Given this list of marker genes Cfap119, Cdin1, Mybl2, Cryl1, Cd247, Fgfr2, Prep, Osm, Pck1, Nhp2, Rasl2-9, Creb3l1, Dusp9, Nova1, Clcn6, Alad, Fbxo22, Vapa, Cox16, Ppp2r5d, Aar2, Zfp933, Phyhip, Ctdsp2, Psmb2, Srf, Mlst8, Ebp, Arf3, Nom1, Chrna4, Gspt1, Zbtb16, Cdh5, Ctsd, BC016579, Nmt2, Rnasek, Babam1, P2rx4, Laptm5, P4ha1, Efhc1, Mdga1 (MAM domain containing glycosylphosphatidylinositol anchor 1), Kdm6b, Zfp992, Tmprss11b, D630039A03Rik, Cdcp3, Lamc1 (laminin, gamma 1), Hcfc1, Ebf3, Arhgap32, Zswim8, Clcf1, Mapkapk2, Kat6a, Elavl2, Mbd6, Cd300ld, Otof, Hsd3b1, Nsd3, Ergic1, Zdhhc9, Atf3, Gnrhr, Tpgs1, Ap1g1, here is a description of the gene set: Genes predicted to be targets of miRBase v22 microRNA mmu_miR_6956_5p in miRDB v6.0 with MirTarget v4 prediction scores > 80 (high confidence targets). Mouse Gene Set: MIR_6956_5P studied in species Mus musculus from publication Chen Y, Wang X (PMID 31504780)